Given this list of marker genes UFL1 (NCBI Gene Id 23376), PTPN1, DNAJB9, HSPA5, BFAR, DDRGK1 (DDRGK domain containing 1), AGR2, BBC3, DAB2IP, TMBIM6, BAX, BCL2L11, TMEM33, BAK1, COPS5, FICD, here is a description of the gene set: Any process that modulates the frequency, rate or extent of the IRE1-mediated unfolded protein response. studied in species Homo sapiens Human Gene Set: GOBP_REGULATION_OF_IRE1_MEDIATED_UNFOLDED_PROTEIN_RESPONSE